The following is a description of a gene set: Binding to a signal recognition particle. Human Gene Set: GOMF_SIGNAL_RECOGNITION_PARTICLE_BINDING species: Homo sapiens, and this is the list of marker genes: SRP68 (signal recognition particle 68), DERL1, DERL3, SRPRA, SRP9, SRP72, RHBDD2, DERL2